The following is a description of a gene set: studied in species Homo sapiens Genes down-regulated in pancreatic cancer cells grown in orthotopic xenograft tumors compared to those grown in vitro. To determine the influence of the microenvironment on changes in gene expression, we did microarray analysis on three variant lines of a human pancreatic cancer (FG, L3.3, and L3.6pl) with different metastatic potentials. The variant lines were grown in tissue culture in the subcutis (ectopic) or pancreas (orthotopic) of nude mice. Compared with tissue culture, the number of genes of which the expression was affected by the microenvironment was up-regulated in tumors growing in the subcutis and pancreas. In addition, highly metastatic L3.6pl cells growing in the pancreas expressed significantly higher levels of genes than did the L3.3 or FG variant cells. Growth of the variant lines in the subcutis did not yield similar results, indicating that the orthotopic microenvironment significantly influences gene expression in pancreatic cancer cells. These data suggest that investigations of the functional consequence of gene expression require accounting for experimental growth conditions. Human Gene Set: NAKAMURA_CANCER_MICROENVIRONMENT_DN from publication Nakamura T, Fidler IJ, Coombes KR (PMID 17210693), and this is the list of marker genes: BCAT1, CCNB2, DHFR, NDUFA9, AGPS, COTL1, KIF2C (kinesin family member 2C), SHROOM3, KNSTRN, TXNRD1 (thioredoxin reductase 1), SLC7A11, BPNT2, TRIP13, PTTG3P, SYNCRIP, RFC5, BUB1, CDC6, PSMG1, FANCI, TNS3, USP39, TCP1, AURKA, LSM4, CDC20, NDC1 (NDC1 transmembrane nucleoporin), SPAG5, PSPH, SLC30A5, HOMER2, KLHL5, PA2G4, MARS1, FAM83D, CARS1, PSAT1, RIPK2, ASNS, TARS1, ARTN, CTH, DHRS3, RFC4, IARS1, CDCA2